The following is a description of a gene set: Human Gene Set: HP_CERVICAL_CORD_COMPRESSION Compression of the spinal cord in the cervical region, generally manifested by paresthesias and numbness, weakness, difficulty walking, abnormalities of coordination, and neck pain or stiffness. species: Homo sapiens Cervical cord compression, and this is the list of marker genes: EP300, IDS, ARSL, RMRP, CREBBP, NFIX, IDUA, EXTL3, COMP